Given this list of marker genes SMOC2, PAPSS2, ABCB8, WFDC1, SULT2B1, NDUFA1, PCDH1, MUC13, RIMKLB, SERPINA12, SMAD7, TM2D2, SELENOP, ADH4, GATB, NR1I3, PFN1, CDT1, SHE, EVI2B, GJA5, PTCRA, HVCN1, SERP1, TNFRSF12A, RELL1, EPHA6, NR4A3, UBE2I, SMPD3, WASF2, SH3GL3, B3GNT2 (UDP-GlcNAc:betaGal beta-1,3-N-acetylglucosaminyltransferase 2), SS18L2, HAX1, FGF22, TNFRSF14, EIF2AK3, ZNF213 (zinc finger protein 213), KMT5B (lysine methyltransferase 5B), CEP89, CAPN5, HCAR2, PIM3, METTL17, SRP14, PTTG1, PLCG1, DUSP1, RFLNB, ABCG4, SEPTIN11, CD28, ABCC3, KCND1, CRIP2, QDPR, SNX18, SRGN, UQCRB, DDIT4L, GSTM2, TRPC5, LPO, CNTD1, PRF1, KAZALD1, SPI1, INSL5, MUC20, C3orf62, KIAA1143, STAM2, TRIM8, SASH3, BOK, ADRA1A, NDFIP1, TCTE1, TMEM37, GDF11, HMGCR, MED11, CBLN1, LRRC8A, ADORA2A, GRID2IP, VSX1, RGS2, WDR26, TFB2M (transcription factor B2, mitochondrial), SPAG7, MED20, ERBB2, PDZK1IP1, TPRN, NMUR2, CDON, CSRP1, DOK1 (docking protein 1), NOLC1, ISL2, TNFAIP8L1, MRPL47, POLG2, EXTL1, ADNP, TIMP2, RECK, SRC, TMCC3, EBAG9, PLK3, SLC3A2, NCBP1, MCM7, GALNT4, RETREG2, MADD, GSTM3, DUSP10, SLC6A12, KCTD17, NELFB (negative elongation factor complex member B), EPDR1, CD2BP2, ATP1A3, TEF, TAS1R2, FFAR2, TGIF1, CREBZF, EVI2A, PDGFRA, NHLH1, PCMT1, SCG3, FKBPL, YTHDF2, RNF103, PHLDA1, MKNK2, RMND5B, ANKRD24, AFF2, UGT3A2, ZAN, RPS6KL1, KCNQ1, FOXI1, TNFSF11, DMTF1, LDLR, TSPAN8, GYPC, TERF2, SGTA, RHOA, FNDC7, OTULINL, HOMER1, TDRP, PLEKHA6, MYO1E, ATP7B, BCL2A1, TCEAL9, ALKBH4, RNF144A, SOX9, CHMP1B, NUP58, TNXB, CCR10, FAM118A, CATSPERG, ST8SIA5, AMHR2, NR2F6, DCTN1, CRB3, ITM2A, RAMP3, IAPP, PYCR2, RHOG, MT2A, MORF4L2, CDCA4, RPIA, PHOX2A, AKR1B10, ZFAND2A, POLR2D, TPD52L1, ALX3, EIF4B, NKX2-8, MOV10L1, CLCF1, here is a description of the gene set: Human Gene Set: GSE15330_LYMPHOID_MULTIPOTENT_VS_PRO_BCELL_UP from publication Ng SY, Yoshida T, Zhang J, Georgopoulos K (PMID 19345118) Regulation of lineage potential and transcriptional priming by Ikaros. New insight is provided into a bivalent regulation of lineage priming in the HSC and its lympho-myeloid restricted progeny the LMPP by the lymphoid lineage-determining factor Ikaros Whereas Ikaros is responsible for the activation of a cascade of lymphoid expression programs and for the establishment of lymphoid potential from the HSC to the LMPP it is also responsible for the repression of stem cell and erythroid genetic programs that are incompatible with further lineage restrictions emanating from the LMPP Genes up-regulated in lymphoid-primed multipotent progenitors versus pro-B lymphocytes. species: Homo sapiens